The following is a description of a gene set: Mouse Gene Set: GOCC_SPHERICAL_HIGH_DENSITY_LIPOPROTEIN_PARTICLE A mature high-density lipoprotein (HDL) particle, converted from discoidal HDL particles following the esterification of cholesterol in the particle by phosphatidylcholine-sterol O-acyltransferase (lecithin cholesterol acyltransferase; LCAT). species: Mus musculus, and this is the list of marker genes: Apoa2, Apom, Pon1, Apoc3, Apoc2, Apoa1, Apoc2l, Clu, Hp